The following is a description of a gene set: Human Gene Set: GOBP_MULTICELLULAR_ORGANISMAL_REPRODUCTIVE_PROCESS The process, occurring above the cellular level, that is pertinent to the reproductive function of a multicellular organism. This includes the integrated processes at the level of tissues and organs. species: Homo sapiens, and this is the list of marker genes: ZPBP, TXNDC8, WDR77, AFG2A, BPY2, CLDN11, PLK1, MERTK, BMPR2, LSM14B, TACR1, PIWIL2, TSPY3, DDX25, SSX1, XRN2, FMN2, DHH, FAM9B, USP26, CFAP221, CDK16, SLIT3 (slit guidance ligand 3), RXRB, SNRPA1, TSPY10, RGS2, CIB1, RACGAP1, ZNF449, FIGNL1, MEIOSIN, KATNAL1, FST, BMAL1, CRISP1, FANCD2, GORASP2, MEA1, PTTG1 (NCBI Gene Id 9232), CFAP69, EDNRB, SP3, SPATC1L, HOXA10, MOV10L1, PTX3, CFTR, LYZL6, TSPAN8, NR3C1, CEP131, MYBL1, NDC1, PRM1, CELF1, TEX15, STAT5A, SLC22A14, DEDD, SOHLH1, GPX4, SOX17, ZNF148 (NCBI Gene Id 7707), HMGB2, GGNBP1, DCST2, PAEP, TEX11, CFAP52, NTRK1, ADA, RBM46, SETX, AGRP, NR6A1, ADAMTS16, TUT4, KPNA6, GJA10 (NCBI Gene Id 84694), FNDC3A, STK11 (serine/threonine kinase 11), PRKACA, HPGDS, CREM, MECP2 (NCBI Gene Id 8274), TSPY1, CATSPERB, NDC80, GHRL, SKIL, CATSPERD, HAVCR2, SPACA5, HEXB (NCBI Gene Id 3074), ZFY, STC2 (NCBI Gene Id 8614), TEKT3, FOSL1, RUVBL1 (NCBI Gene Id 8607), SPATA31D4, MSH4, NLRP14 (NCBI Gene Id 338323), ADCYAP1R1 (NCBI Gene Id 117), BMPR1B, TTLL5, SLC2A8, PANX1, STRA8, BCL2L1, GGN, UTP14C, FAM9C, FSIP2, YY1, CYP27B1, NHLH2, ZC3H14, EDDM3A, SPATA20, FREY1 (NCBI Gene Id 143678), ADAM2, TPGS1, KMT2D, EQTN, METTL14, FUT6, FOXL2, PI3, ODF4, SLC9A8, SLC2A14, ADIG (NCBI Gene Id 149685), TSPY8, IMMP2L, ZMYND12, PHC2, TRIM27, ZSCAN21 (NCBI Gene Id 85010), LIF, SBF1, P2RX1, ADAM28, AP3B1, SPATA31A5, UCHL1 (NCBI Gene Id 7345), GABRB1, PTCH1, SEBOX, CTSB, LIMK2, SPACA3, SPMIP6, CALR3, DRC1, RAI14, ADGB, HSF2BP, NEURL1, TGFBR1, NEURL4 (NCBI Gene Id 84461), OAZ3, PACRG, CHN2, SEPTIN14, SPATA31A6, PTGDR2, AZIN2, NOTCH1, MKRN2, RPS6KA2, FANCL (FA complementation group L), SELENOF, PAQR5, MTOR, DCST1, GMCL2 (NCBI Gene Id 64396), WIPF3 (NCBI Gene Id 648464), TRIM75, VPS54, DIRAS3, OXT, LGR5, TSPY4, CEP128, FOLR1, TGFB3, ATN1, PRDX3, COX7B2, TTK, CCDC34, IQCG, SPIN2B, SOX9, SLC25A31, EHMT2, TSPY9, DDX4, DNALI1, VCX, TCP11X1, STAU2, ZBTB16, OVOL1, CLOCK, KNL1, PYGO1, FER, DPY19L2P2, TGFB2, ACVR2A, SPATA31D1, SEPTIN12, MTNR1A, CCDC146, PRMT7, CASP2, SPAG6, SPAG8, NR2C2, SPACA1, MASTL (microtubule associated serine/threonine kinase like), MDK, BMP4, CFAP57, DRD5, FOXJ3, SEPTIN6, HOXA11, TCFL5, AKT1, USP9Y, PLN, CCIN, KLHL10, NICOL1, RAD51C, FUOM, ASPM, FANCG, BRCA2, TMEM119, SPATA32, CTCF, MROH2B, PAFAH1B3, TBC1D20, CBY3, GLI1, TCP11X2 (t-complex 11 family, X-linked 2), ZSCAN2, SPATA6L, TDRD9, RIMBP3C, EIF4G3, LDOC1, P2RY1, MMP2, FOXJ2, MEIOC, SPATA25, IFT20, SPATA6, CDC25B, M1AP, ADAM18, ASH1L, MAJIN, TUBB8, REC114, ICA1L, PDE3A, YTHDC1, PRDX4, ARRDC5, BOLL, CFAP91, LARP7, RAN, CREB3L4, MYCBP, GDF9, DND1, SYNE1, NKAPL, PTGDS, ATM, SEPTIN7, AVPR1A, TBATA, NPM2, CATSPER1, ITGB1, RNF17, ACVR1, SPMAP2, WNT3, FBXO5, DNHD1, CAPZA3, CNTD1 (cyclin N-terminal domain containing 1), SPATA9, BRDT, TSNAX, PGR, BCL2L10, ZNF35, HROB, PRM3, PARP1, PSME4, CEP57, POC1B, CCNB1, ASZ1, CFAP61, ODF2, CFAP53, FOXO3, ROPN1B, APOB, VDR, TDRD5, TTC12, DDB1, GARIN3, KIT, SLC9C1, SERPINE2, ABAT, NPFF, HERPUD2, DDO, SPINK2, HSPA2, SPATA46 (NCBI Gene Id 284680), FIGLA, FOXC1, SPEM1, KDM2B, SMAD1 (NCBI Gene Id 4086), ACSL4, KIAA0319L, ALKBH5, ACE, BCAP31, PAIP2, TP63, ADCY10, DAZ3, TMF1, GJA1, SYCE3 (synaptonemal complex central element protein 3), ATAT1, DAZAP1, PARN, CTNNB1, CXADR, TAF4B, ZCWPW1, CFAP58, ZNF541, ACRV1, MED1, NCAPH, QKI (QKI, KH domain containing RNA binding), USP9X, ARID4A, HMGA2, MBD2, STAU1, BBOF1, HPGD, PDGFRA, PRM2, TDRD12, SUN5, BTG1, GARIN4, PTGIS, RPL10L, OR7C1, NR0B1, OXTR, WFDC2, CDY2A, EGR1, PAX5, PAQR8, TOP2A (DNA topoisomerase II alpha), CCNI, FAM209B, SPATA31C2, PAFAH1B1, DAZ2, TCP11, AMH, ZAR1L, TBPL1, UBE2B, SEMG2, WDR54, FZD4, CIMAP1A, SERPINA5, LRRC46, INHBA, YTHDF2, ANG, CRTAP, LIN28A, TDRD1, NPHP1 (nephrocystin 1), SLC6A4, NDRG3, SMAD5, APOL2, SPAM1, IZUMO3, CDKN1C, SHCBP1L, CCNB1IP1 (NCBI Gene Id 57820), MGAT4D, RETN, DSG2, ACE2, NR5A1, TYRO3, PITHD1, NPR2 (natriuretic peptide receptor 2), CCR6, CCDC136, PCNA, GAL, FOXJ1, ZNF628, ZNF296, DMRTA1, RHBDD1, IFT81, PYGO2, MEIG1, ARMC3, SLIRP, HSF2, WDR33, SPINK1, ING2, KIF18A, HERC2, DCAF17, KDM1B, IGF2R, EIF5A2, CCNB2, ZPBP2, KDM3A, PDCL2, PPP1R1B, PTPRN, RIMBP3, EDN1, NOX5, ODAD3, PRSS42P, ARID4B, TARBP2, SEMG1, ZP3, DNMT3L, SPATA22, MKKS, KLF1, NOS3, GABRB3, ELSPBP1, PRKG1, IFTAP, NANOS1, IQCF1 (IQ motif containing F1), BPY2C, TSSK6, MEIOB, CCNO, CELF3, PIWIL4, CELF4, CABYR, HORMAD1, TNFAIP6, TLE6, SPEF2, IZUMO1R, DDX6, PUM1, ASF1B (NCBI Gene Id 55723), TMEM95, DEFB118, SPATA31D3, SRPK1, PDILT, GTSF1, CCDC87, TESK1, RFX2 (regulatory factor X2), FSHR, CNTLN, PPP2R1A, DMRTC2 (NCBI Gene Id 63946), ORC4, ACOX1, AR, GAL3ST1, ADAD1, SLIT2, SPACDR, NPPC, TDRD6, ELL3, SPP1, SASS6, GSK3A, PGM3, AGO4, TCF23, SERPINF1 (NCBI Gene Id 5176), HERC4, DNAH1, PCDH11Y, JAG2, DRD1, CYP26B1, SHISA6, CYP1A1, HAS2, CFAP47, NANOS2, ITGA3, JUNB, DNMT3A, CDY2B, TTLL3, H3-3A, GMNC, EED, MYCBPAP, CA12, GHRHR, TPPP3, PAQR7, IHH, RIMBP3B, TUBA8, CDYL (NCBI Gene Id 9425), FOLR2, GK2, TESMIN, PIK3CA, TDRP, SPATA24, BIRC3, ESR1, DMC1, CGB7, GARIN1A, BAX, IZUMO1, TTLL8, SLC19A2, KRT9, SPACA6, MCMDC2 (minichromosome maintenance domain containing 2), NR5A2, MSH6, PCSK4, OCA2, C16orf92 (NCBI Gene Id 146378), TNP2, SLC22A16 (NCBI Gene Id 85413), EFCAB9, UBB, SPIN2A, AXL, ZMYND15, DLD, ADAM29, WEE2, HADH, FAM50A, PRDM1, ADAMTS2, TDRD7, SPIN4, SSH2, DRC7, TMEM203, SOX8, DLEC1, SKA3 (spindle and kinetochore associated complex subunit 3), AVP, MEIKIN, HOOK1, CASP3, TPPP2, WT1, SPAG17, SPA17, WASHC5 (NCBI Gene Id 9897), GALNTL5, SEPTIN1, CCDC42, SPATA16, PLA2G3, PARP11, LYZL4, TBP, AGFG2, H3-4, SLCO4C1, MORN2, BTBD18, CADM1, SPOCD1, ENSG00000274276, BBS2, NDP, LLCFC1, PPP1R9B, CD9, PRDM9, BAG6, TSSK3, RBMY1B, TNP1, BSPH1, CSNK2A2, SLC26A3, HDAC2, EIF2S2, SPATA2, HYAL3, SMARCA2, CGA, TERB2, TUT7, TXNRD3, TESK2, RNF114, H2BC1, MCM8, RBX1, ADAM7 (NCBI Gene Id 8756), MSH2, TAC1, PTGS2, EREG, CUL4A, UBR2, CFAP54, MAPK8IP2 (mitogen-activated protein kinase 8 interacting protein 2), DMRT1, PIWIL3 (piwi like RNA-mediated gene silencing 3), SPACA5B, SYCP3, PROK2, ARMC2, SOX30, RNF8, H1-6, ZDBF2, STOX2, DPY19L2, SKA2, NME8, HCN1, RBP4, NODAL, SLC26A8, GAS2, BCL6, MSTN, YBX2, CCNA1, ROPN1L, PMCH, MAST2, ATRX, KAT5, TDRKH, NECTIN2, SYCP1, PANK2, THRB, CNBD2, NPY5R, RAD23B, NOBOX, STC1 (stanniocalcin 1), IFT27, MMP19, CATSPER3, LHCGR, PIAS1, SMAD4, NR2F2, OOSP2, GDF10, CCNYL1, DPCD, SIAH1, JAM2, BCKDK, BCL2L11 (BCL2 like 11), FBXW11, IGF1 (insulin like growth factor 1, NCBI Gene Id 3479), DDX3Y, CDY1, SHB, PLD6, DAZ4, DEAF1, DAZ1, TXNDC2, RXFP2, ABHD2, TSSK2, DDX20, CALR, PFN4 (profilin family member 4), APP, ETV6, SFMBT1, BMP15, CABS1, H1-7, H1-9P, B4GALT1, TH, TSSK1B, ADCY7, LRRC8A, GAMT, SYCP2, ARMC12, SIRT2, BCL2, TTLL1, ZFP41, SPEM3, TMPRSS12, CATSPER4, SPIRE2, CFAP65, RB1, DKKL1, NRIP1, STAT5B, VDAC3, IFT56, SKA1, CCNY, CFAP157, BNC1, SPAG11B, WNT4, KLK14, BRINP1, PTEN, IFT25, YBX3, RAB24, AXDND1, AKAP4, SPIRE1, CFAP206, MORC1, TSNAXIP1, HOATZ, TBC1D21, PRDM14, MOS, VPS13B, IQCN, OSBP2, TEX19, MCIDAS, NOTCH4, WDR48, AURKA, SRC, CFAP119, CCDC62, STK33, IGF2, FSHB, MTA2, ERCC1 (NCBI Gene Id 2067), SPESP1, TMED2, FAM9A, HOXA9, SLC4A2, SEPTIN2, C2CD6, PSMA8, CFAP44, ZAR1, SEPTIN4, CHD5, MFSD14A, CREBRF, OPRK1, SCAPER, DUSP13B, DSG1, CSMD1, EPC1, SPATA31A7, ZNF830, JAM3, RARA, NME5, KHDRBS1, KIFC1, GPR149, ATP1A4, GNRH1, LZTFL1, CIBAR1, H3-3B, SIRT1, FBXO24, NUP210L, SPIN3, SUFU, GGNBP2, CGB3, ACTL9, CCDC63, ACR, E2F1, ROS1, CYLC1, SUN1, PTN, NPAP1, SPANXA2, ACSBG2, CYLC2, BSG, FOLR3, AGFG1, RPL39L, STRBP, CTCFL, TPST2, KASH5, TTC21A, CATSPERE (NCBI Gene Id 257044), CFAP97D1, ROBO2, TRIM28, PRKAG1, NDN, ADNP, INPP5B, SOD1, BCL2L2, LEP, TEX14, MAK, CBS, CT55, CRKL, MEI4, SPATA31C1 (NCBI Gene Id 441452), DHX36, USP42, SPATA31A3, PPP1CC, PGAM2, SPATA19, PRKACG, SSTR1, PRSS21, DZIP1, BRD2, SPMIP7, PPARD, PCYT1B, CITED2, MYCN, RSPH1, BPY2B, SPIN1, ODF1, PARP2, AFP, PATZ1 (POZ/BTB and AT hook containing zinc finger 1), PMFBP1, PAFAH1B2, METTL3, KAT8 (NCBI Gene Id 88034), CFAP43 (cilia and flagella associated protein 43), FANCA, TGFB1, LRRK2, KCTD19, CCER1, MLH1, UPF3A, THRA, INSL3 (insulin like 3), CCDC159, DIAPH2, LRGUK, NPAS1, REC8, MCM9, SPAG16, MARF1, C3orf62 (NCBI Gene Id 375341), YTHDC2, RPS6KB1, CDY1B, DEFB1, INHBB (inhibin subunit beta B), TRIP13, ETV5, SMCP, KLC3, GLIPR1L1, HSF5, BRIP1, PPP3R2, TSGA10 (NCBI Gene Id 80705), PRSS37, CTDNEP1, GMCL1, FEV, DBH, ADGRG2, NCOR2, ANKRD49, BBS4, GALNT3 (NCBI Gene Id 2591), H2AX, DYNLL1, FKBP6, YIF1B, H1-1, ACTL7A, CETN2, ADAD2 (NCBI Gene Id 161931), TAF7L, NSUN2, ATP2B4, NCOA1 (nuclear receptor coactivator 1), IHO1, ROPN1 (NCBI Gene Id 54763), FAM209A (family with sequence similarity 209 member A), UBE2Q1, NANOS3, FXR1, DCAF13, CATSPERG, TOPAZ1, SPANXA1, ZFP57, SIX5, TOB2, EDNRA, BCAS2, SPATA31E1, SOS1, GARIN1B, RNF2, ACRBP, C14orf39, ANGPT2, TSSK4, SPAG4, CATSPERZ, DAZL, HSF1, SPDYA, ADAMTS1, DDX3X, MNS1, CCDC38, LGALS9, RSPH6A, TSPY2, CTSH, PNLDC1 (NCBI Gene Id 154197), RNF151, HMX3, LGR4, UBE2J1, PLEKHA1, DNAAF3, PIWIL1, MAEL, CATSPER2, MLH3, VIPAS39, TMEM232, SPANXB1, SOHLH2, SPPL2C, FOXA3, SGPL1, ZMIZ1, EMP2, SPATA31A1, BRME1, GHSR, AFF4, EPOR, NCAPH2, ZGLP1, TAF1L, POC1A, SLC26A6, B4GALNT1, GGT1, SPO11